The following is a description of a gene set: Mouse Gene Set: MIR_6911_5P from publication Chen Y, Wang X (PMID 31504780) studied in species Mus musculus Genes predicted to be targets of miRBase v22 microRNA mmu_miR_6911_5p in miRDB v6.0 with MirTarget v4 prediction scores > 80 (high confidence targets)., and this is the list of marker genes: Gnat2, Gpr25, Sema5b, Fzd4, Rgs14, Thsd4, Ubn1, Casp14, Kremen1 (kringle containing transmembrane protein 1), Etv5, Pramel21, Sec14l1 (NCBI Gene Id 74136), Znrf1, Vamp2, Gm4847, Kcnv2, Iqsec1, Efhd2, Nptx1, Zfp764l1, Bpifb9a, Galnt6, Zfp568, Atf7ip, Pak5, Ucp2, Slc25a21, Txlna, Trarg1, Vipr2, Neu2, Tal2, AW551984, Zhx3, Csnk1g1, Unc5b, Sae1, Cnksr2, Rfxap, Vtcn1, Reep3, Asb8, Irgm2, Sdc3, Mcf2, Pik3c2a, Tef, Pum2, Samd4b, Cyp26b1 (cytochrome P450, family 26, subfamily b, polypeptide 1), Nck1, Rac1 (Rac family small GTPase 1), Nck2 (NCBI Gene Id 74592), BC035044 (NCBI Gene Id 232406), Dlg2, Tmem200b, Mkx, Nkain2, Hs3st3b1, C1qtnf6, Rreb1, 5031439G07Rik, Cxcl16, Larp1, Nectin1, Polr1f, Chrna3, Bpifb9b, Crbn, Naa80, Fnip2, Tsc2, Zfp821, Slc8a1, Usp14, Serpinb10 (NCBI Gene Id 98753), Sestd1, Ppp2r5d, Clcnka, Jade2, Flot1, Mdga1, Slc25a14, Abraxas2, Tagln, Mllt6, Tspan7 (NCBI Gene Id 97622)